The following is a description of a gene set: Mouse Gene Set: GOCC_PHAGOCYTIC_VESICLE A membrane-bounded intracellular vesicle that arises from the ingestion of particulate material by phagocytosis. species: Mus musculus, and this is the list of marker genes: H2-T3, Ambra1, Appl1, Rab11a, Calr, Adam8, Hvcn1, Kif16b, Rab12, Pld4, Havcr1, Slc15a2, Stxbp2, Slc9a9, Mpeg1, Coro1a, Nod2, Vamp4, Fmnl1, Rab14, Nod1, Ctss, H2-T23, H2-K1, Tap1, Cybb, Inpp5b, Pip4p1, Vim, Mtmr4, Stxbp3, Pik3c3, Rab22a, Rab11fip5, Abca1, Kif5b, Trim14, Ocrl, Tcirg1, Tapbp, Rilp, Rab23, Rnf115, Pip4p2, Stx11, Syt7, Anxa3, Syk, Gsn, Unc13b, Tlr7, H2-Q10, Capg, Zyx, Lamp1, Lamp2, Stx6, Rab8a, Rab31 (RAB31, member RAS oncogene family), Rab11fip1, H2-D1, Scimp, Stx8, Rab7, Appl2, Rab8b, Mtor, Flnb, Cdc42ep2, Tlr9, Tlr6, Rab11b, Rab9, Cd82, Sec61a1, Rab9b, Irgm1, Rab38, Vamp3, Stx12, Tlr2, Evl, Vps26b, Rapgef1, Lrrk2, Clec4e, Actg1, Myh9, Rab10, Pfpl, Tlr1, Stxbp4, Rab32, Myo18a, Zdhhc5, Anxa11, Cdc42ep4, Unc93b1, Slc48a1, Srgap2, Myo1c, Was, Pla2g5, Clcn3 (NCBI Gene Id 12725), Syt11, Rab20, H2-Q7, Mcoln1, Rab7b, Uvrag, Rab34, B2m, Pikfyve, Dnm2, Becn1, Slamf1, Rap1a, Stxbp1 (NCBI Gene Id 98927), Rab5a (RAB5A, member RAS oncogene family), Rab39, Vamp8, Slc11a1, Rab43, Atg14, Stx4a, Dmbt1, Snx3, Cdc42